Given this list of marker genes STON2, BTBD8, CLTC, EPS15L1, STON1, PICALM, CLTB, EPS15, SGIP1, SYNJ1, AP2M1, AP2A1, TBC1D5, SLC18A3, AP2S1, CLTA (clathrin light chain A), AP2A2, AP2B1, here is a description of the gene set: The coat found on coated pits and the coated vesicles derived from coated pits; comprises clathrin and the AP-2 adaptor complex. studied in species Homo sapiens Human Gene Set: GOCC_CLATHRIN_COAT_OF_COATED_PIT